Given this list of marker genes CYP17A1, here is a description of the gene set: Steroid 17-alpha-hydroxylase/17,20 lyase (CYP17A1) mediates both 17-alpha-hydroxylase and 17,20-lyase activity, allowing the adrenal glands and gonads to synthesise both 17-alpha-hydroxylated glucocorticoids and sex steroids respectively. Defects in CYP17A1 can cause Adrenal hyperplasia 5 (AH5), a form of congenital adrenal hyperplasia (CAH), a common recessive disease due to defective synthesis of cortisol and sex steroids. Common symptoms include mild hypocortisolism, ambiguous genitalia in genetic males or failure of the ovaries to function at puberty in genetic females, metabolic alkalosis due to hypokalemia and low-renin hypertension. CYP17A1 can have defects in either or both of 17-alpha-hydroxylase and 17,20-lyase activities thus patients can show combined partial 17-alpha-hydroxylase/17,20-lyase deficiency or isolated 17,20-lyase deficiency traits. part of: Metabolic disorders of biological oxidation enzymes Reactome Pathway: Defective CYP17A1 causes AH5 studied in species Homo sapiens